The following is a description of a gene set: Mouse Gene Set: HEVNER_CORTEX_RADIAL_GLIA_PROGENITORS from publication Bedogni F, Hevner RF (PMID 34321999) species: Mus musculus Genes selectively expressed by radial glia progenitors in embryonic day 14.5 mouse cortex, and this is the list of marker genes: Pif1, Pdcd4, Nup133, Etv1, Ttyh1, Nr2e1, Hes5, Prpf3, Ifngr1, E2f8, 2010204K13Rik, Tinf2, Vamp3, Man1a2, Dbi, Nxn, Nbn, Scara3, Rhoa, Qki, Dnmt3a, Mtln, Mob1a, Mcm6, Rbl1, Sall1, Ndufaf8, Tcf7l2, Gpsm2, Aldh9a1, Phgdh, Abl1, Sypl1 (NCBI Gene Id 52577), Spata13 (spermatogenesis associated 13), Mtap (methylthioadenosine phosphorylase), Tcf7l1, 2610316D01Rik, Akr7a5, Bcl7c (B cell CLL/lymphoma 7C), Pclaf, Mob3b, Nfatc4, Ptbp3, Cntrl, Rgs3, Mcm5 (NCBI Gene Id 194478), Ccnq, Tacc3, Cep192, Lig1, Btd, Aspm, Pard3b (NCBI Gene Id 72823, par-3 family cell polarity regulator beta), Fhl1, Larp7, Cdca7l, Arhgef40, Eif4ebp1, Scarb1, Litaf, Prc1, Foxm1, Pitrm1, Vim, Crb2, Stxbp3, Wee1, Ednrb, Tbc1d31, Creb5, Cdc45, Mcm2, Stil, Elp4, Dag1, Knstrn, Mtmr10, Ssrp1, Acot1, Mxd3, Zfhx4, Ttk, Exosc8, Usp1 (NCBI Gene Id 230484), Bcan, Dscc1, Cenpm, Lima1, Rbbp7, Gng5, Hells, Arhgef39, Cdca5, Paics, Emid1, Fam83d, Kif20b, Pdlim4, Pold1, Asxl2, Rpa2, Selenoh, 2310039H08Rik, Rgs20, Fgfr2, Cdca7, Timeless, Pola1, Kat7, Btg1, Kif4, Nde1, Sema3a, Rfc2, Ubr7, Sgo1, Ccdc34, Dock1, Tyms, Tox3, Bola3, Gmnn, Ube2t, Ccnf, Itgav, Ercc6l, Cdk1, Lbr, 2810459M11Rik, Mcm10, Cand2, Tead1, Fanca, Cip2a, Oip5, Prkd1, Cmss1, Notch3, Cenpn, Prim2, Pacsin3, Lrr1, Ndc80, Ctnna1, Dbf4, Dlgap5, Rela, Racgap1, Ppm1m, Pole2, Rest, Mest, Ttf2, Tsc22d4, Igfbp5, Acss1, Pea15a, Mthfd2, Tifa, Sp1, Exo1, Kntc1, Haus1, Cdkn2c, Kif11, Cenpe, Plod2, Bub1b (BUB1B, mitotic checkpoint serine/threonine kinase), Rpp25l, Fam167a, Rfc4, Ccna2, Dnmt1, Pbk, Glul, Txndc5, Eepd1, Rfc3, Nelfe, Dhfr, Pter, Sox1, Dtl, Snx5, Pnp, Rras, Pnrc2, Bptf, Cep76, Ncaph, Cldn12, Tmem165, Gas1, Pcgf5, Fat1 (FAT atypical cadherin 1), Nudt5, Cenpu, Rfx4, Asah1, Mfge8, Prim1, Melk, Cgrrf1, Fbxo5, Sox9, Asrgl1, Slbp, Rnaseh2c, Tex9, Mis18a, Ngdn, Gins1, Med6, Naa38, Mid1, Rgcc, Mad2l1, Clspn, Cenpl, Prdm5, Cdc6, Mgst1, Tmem123, Sox2, Gulp1, Gpx8, Mcm7, Ncapg, 2810025M15Rik, Spc24, Tacc1, Tns3, Gcsh, Aurka, Dusp16, Abhd4, Kif23, Rnaseh2b, Vcam1, Specc1, Dkc1, Mavs, Tjp2, Itgb8, Cnih4, Neil3, Fancd2, Prokr1, Cenpq, Tjp1, Ska1, Gk, Pold3, Ctse, Efnb1, Hadh, Alg8, Shmt1, Espl1, Ranbp1, Mthfd1, Tpx2, Mcm3 (minichromosome maintenance complex component 3), Cit, Prps2, Mtarc2, Ift74, Mrpl39 (mitochondrial ribosomal protein L39), Pole, Mis18bp1, Mrpl35, Mns1, Wasf2, Hsd17b10, Top2a, P2rx7, Asxl1, Snhg8, Wdhd1, Hat1, Notch2, Nusap1, Trip13, Smad3, Dnmt3b, Smoc1, Vit, Ppp1r1a, Iqgap2, Eme1, Prkd3, Tspan12, Ccdc102a (coiled-coil domain containing 102A), Hspa14, Cenpa, Mt1, Ccn1, Eldr, Nudt1, Sall3, Fkbp14, Rfc1, H1f2, Shcbp1, Cdca2, Zeb1, Chek2, Incenp, 2810004N23Rik, Pkmyt1, Nlk, Fignl1, Ccdc86, Cenpk, Tgfb3, P4ha3, Atp1a1, Timm44, Ccnb2, Sox2ot, Haspin, Spred1, Mms22l (MMS22-like, DNA repair protein), Rad51ap1, Casp7, Cadps2, Blm, Ddah1, Snx8, Uhrf1, Mcm4, Cdt1, Msl3, Tgfb2, Aif1l, Cenpp, Mybl2, Gas2l3, Tbl1x, Firrm, Klhl13, Nuf2, Chek1, Ino80b, Nup85, Nek7, Ccnd1, Ccdc80, Rad51, Slc1a3, Gabpb2, Sox21, Gca, Id4, Tnfaip8, Pask, Jam2, Tfap2a, Lrp4 (NCBI Gene Id 277398), Zfyve21, Plekha7, Vegfc (vascular endothelial growth factor C), Spc25, Efhd2, Metrn, Nfic, Asf1b, Slc26a7, Megf10, Rpain, Ide, Sema5b, Cdca3, Birc5, Ak3, Prr11, Arl6ip4, Smpdl3a, Adgrv1, Rpa1, Tulp3, Tbc1d4, Tab2, Parpbp, Lpar1, Fanci, Brca2, Anln, Atr, Dsn1, Mrpl13, Phactr2, 9130401M01Rik, Cdca8, Aurkb, Igdcc4, Fgfbp3, Notch1, Rrm2, Commd1, Nfkb1, Ripk1, Knl1, Glo1, Ccne2, Prkcb, Nsmce2, Yap1, Lrp2, Ccne1, Zwilch, Dtymk, Gli3, Pawr, Fen1, Aebp2, Cmc2, Plk1, Spag5